The following is a description of a gene set: Microtubule depolymerization at the minus ends. Pathway ID: N01562. Pathway type: Reference. Pathway class: nt06515 Regulation of kinetochore-microtubule interactions. Pathway Definition from KEGG: PLK1 -> KIF2A == DDA3 == microtubule studied in species Homo sapiens Human Gene Set: KEGG_MEDICUS_REFERENCE_MICROTUBULE_DEPOLYMERIZATION_AT_THE_MINUS_ENDS, and this is the list of marker genes: TUBB4B, TUBA1A, TUBB1, TUBB4A, TUBB, TUBB2A (NCBI Gene Id 92919), TUBA1B, TUBB8, TUBA3E, TUBA3D, TUBB6, TUBA1C, TUBA8, TUBB3, TUBA4A, PSRC1, TUBA3C, PLK1 (NCBI Gene Id 5347), KIF2A, TUBB2B